Given this list of marker genes NAA80, GNAI3, GUSB, HEPHL1, EDN1 (endothelin 1), GPR101 (G protein-coupled receptor 101), ZFX, PLCB4, AHDC1, here is a description of the gene set: Human Gene Set: HP_SNORING Deep, noisy breathing during sleep, accompanied by hoarse or harsh sounds, is caused by the vibration of respiratory structures, especially the soft palate. This vibration results in sound due to obstructed air movement during breathing while sleeping. studied in species Homo sapiens Snoring